The following is a description of a gene set: Human Gene Set: MORF_TFDP2 Neighborhood of TFDP2 species: Homo sapiens Neighborhood of TFDP2 transcription factor Dp-2 (E2F dimerization partner 2) in the MORF expression compendium, and this is the list of marker genes: SULT2B1, GYPA, COLGALT2, SUPT3H, CYP2E1, KRT2, TIE1, CTRL, SLC6A11, NFAT5, HOXD4, GPR18, ABCB10, PRELID3A, IQCK, PLEKHB1, BRD1, SPA17, IRF2, FUT6, PIK3CB, IVL, ABO (ABO, alpha 1-3-N-acetylgalactosaminyltransferase and alpha 1-3-galactosyltransferase), NF1, BNIP1, FIG4, POU6F1, MAGEA9, CYP11A1 (NCBI Gene Id 1583), LCOR, SURF2, MAPT, ZNF592, MFN1, SYT5, IL11RA, ATP8B1, BCL2, PAX9, HOXD13, GJB5, PVR, GH1, OPLAH, PDE4D, CDYL, CPB2, PPP2R5B, EN2, KANK3, PTBP3, NXPE3, MDM2, CADM4, ATF2, ART1, EPHB2, SULT4A1 (NCBI Gene Id 25830), GRIK5, AQP5, KRT86, P2RY10, ATF7, ZNF266, IDS, CELA2B, ZNF33B, POU6F2, ABCB9, FNTB, ELAVL2, TBX19, AMMECR1 (AMMECR nuclear protein 1), PAXIP1, CD6, ZNF157, PSMF1, FRYL, MSL3, MC5R, COX6A2, RB1CC1, RAD51D (RAD51 paralog D), ZNF141, ASB4, ABCC8 (NCBI Gene Id 6833), KHK, PHF10, ATP6V0A2, KLHL18, PIGR, ITIH3, ZNF500, WIPF2 (WAS/WASL interacting protein family member 2), NPFF, NEUROD2, TANC2, RAP2C, STK17A, DGCR5, SIM2, FOSL1, BRCA1 (BRCA1 DNA repair associated), PIK3C2A, IFT27, FGF18, ARL3, GTSE1, FRY, MYOZ3, POLR2K, HTR7, CYP4F2, H3C6, HIC2, CAMK4, SLC22A6, GPR3, CNKSR1, CACNB1, MON2, TBX5, IL16, TRIM24, FLT1, CASP10, BCL2L11, RPS6KA5, GPLD1, PPP1R1A, GNPAT, SLC33A1, KRR1, SP140 (SP140 nuclear body protein), BMP10, RXRG, AMOT, PIAS2, TMEM11, SCAPER, CYP2D6, MLLT10, PITPNA, TPD52, ZBTB40, RUNX2, IL13, SGPL1, AQP7, USP20, CRHR1, ADCY3, OSBP, GPR19, ERC1, CDC73, SLC16A5, YAF2, WT1, ESR1 (estrogen receptor 1), SLC18A1, NR2C1, ZBTB22, FAS, TMEM26, CAMK2G, PTEN, DPT, WBP4, SERPINA4 (serpin family A member 4), SLC4A8, ZP2, DBT, SLC4A3, RREB1, GLE1, NR1I2, GPATCH8, ERC2-IT1, POFUT2, DRC3 (NCBI Gene Id 83450), MSX1, CEACAM4, DOCK1, EXTL3, C1orf216, ATXN3, CCKAR, PRKACA, IRS2, FSHR, PTPRB, POLR3D, DNAJC16, OPRL1, NRTN, KNG1, PSG1, TBC1D22A, BARX2, S100A5, NTNG2 (netrin G2), HCRT, AOC4P, MT4, ZBTB33 (zinc finger and BTB domain containing 33), HNF1A, PGM3, NRP2, JRK, TFDP2, MSH3, LTBP4, ERCC4, LY9, SLC2A1 (solute carrier family 2 member 1), ZNF134, SKI, ATP6V1B1, NOS2, COL19A1, CFH, ECE1, COQ7, KRT33A, GRIP2, PRIM2, IGKV7-3, TSSK2, SMYD5